The following is a description of a gene set: Catalysis of an oxidation-reduction (redox) reaction in which NADH or NADPH acts as a hydrogen or electron donor and reduces a quinone or a similar acceptor molecule. Human Gene Set: GOMF_OXIDOREDUCTASE_ACTIVITY_ACTING_ON_NAD_P_H_QUINONE_OR_SIMILAR_COMPOUND_AS_ACCEPTOR species: Homo sapiens, and this is the list of marker genes: NDUFV1, CRYZ, NDUFB10, NDUFA7 (NCBI Gene Id 4701), NDUFS7, NDUFA1, MT-ND5, AKR1C2, NDUFS3, NDUFB3, AKR1C1, MT-ND4L, NDUFA6, NDUFA8, NDUFB9, NDUFA4, NDUFA3, CBR3, CRYZL1, NDUFS1, TP53I3, NDUFB6, NQO1, CBR1, ADH4, AIFM2, AKR1C4, MT-ND4, NDUFC1, NDUFS2, NDUFV2, NDUFB5, DHRS4, NDUFB4, NDUFA5, NDUFB1, NDUFA10, NDUFA9, NDUFS5, NDUFB2, NQO2, MT-ND1, CBR4, DCXR, MT-ND3, NDUFS4, NDUFS8, NDUFC2, NDUFA12, NDUFS6, RTN4IP1, MT-ND6, NDUFB8, AKR1C3, MT-ND2, NDUFV3, NDUFB7, NDUFA2